Given this list of marker genes IGFBP6, CYP24A1, RSPO3, NRG1, CD44, TGFBI, AHNAK, CDH1, WNT7B, DKK1, BCL2A1, DUSP1, KLF5, RASSF2, DKK3, CRIM1 (NCBI Gene Id 51232), BIRC3, PPP1R14A, SOCS3, FGFR1, SEMA3C, CYP1B1, ADGRG2, AXL, here is a description of the gene set: Genes down-regulated in A549 cells (lung cancer) upon expression of ASCL1 off a viral vector. The proneural basic-helix-loop-helix protein achaete-scute homologue 1 (ASH1) is expressed in a very limited spectrum of normal and cancerous cells in a lineage-specific manner, including normal pulmonary neuroendocrine cells and lung cancer cells with neuroendocrine features. Our previous results indicated that ASH1 may play a crucial role in the growth and survival of lung cancers with neuroendocrine features, which prompted us to investigate the molecular function of ASH1 in relation to its involvement in carcinogenic processes. Herein, we report for the first time that ASH1 functions as a dual transcription factor by activating neuroendocrine differentiation markers and also repressing putative tumor suppressors. This protein was found to inactivate DKK1 and DKK3, negative regulators of Wnt/beta-catenin signaling, E-cadherin, and integrin beta1 through ASH1-mediated deacetylation and repressive trimethylation of lysine 27 (H3K27me3) of histone H3 in the promoter regions of DKK1 and E-cadherin. In addition, ASH1-transduced A549 adenocarcinoma cells exhibited markedly altered morphology characteristics compared with lung cancer cells with neuroendocrine features both in vitro and in vivo and also grew faster in vivo. Our results provide important clues for a better understanding of the molecular and cellular biological roles of ASH1 in the process of carcinogenesis of lung cancers with neuroendocrine features and warrant future investigations to shed light on the lineage-specific dependency of this transcription factor with dual functions. species: Homo sapiens from publication Osada H, Tomida S, Yatabe Y, Tatematsu Y, Takeuchi T, Murakami H, Kondo Y, Sekido Y, Takahashi T (PMID 18339843) Human Gene Set: OSADA_ASCL1_TARGETS_DN